The following is a description of a gene set: Although heme is synthesised in virtually all tissues, the principal sites of synthesis are erythroid cells (~85%) and hepatocytes (most of the remainder). Eight enzymes are involved in heme biosynthesis, four each in the mitochondria and the cytosol. The process starts in the mitochondria with the condensation of succinyl CoA (from the TCA cycle) and glycine to form 5-aminolevulinate (ALA). The next four steps take place in the cytosol. Two molecules of ALA are condensed to form the monopyrrole porphobilinogen (PBG). The next two steps convert four molecules of PBG into the cyclic tetrapyrrole uroporphyringen III, which is then decarboxylated into coproporphyrinogen III. The last three steps occur in the mitochondria and involve modifications to the tetrapyrrole side chains and finally, insertion of iron. In addition to these synthetic steps, a spontaneous cytosolic reaction allows the formation of uroporphyringen I which is then enzymatically decarboxylated to coproporphyrinogen I, which cannot be metabolized further in humans. Also, lead can inactivate ALAD, the enzyme that catalyzes PBG synthesis, and ferrochelatase, the enzyme that catalyzes heme synthesis.<br><br>The porphyrias are disorders that arise from defects in the enzymes of heme biosynthesis. Defective pathway enzymes after ALA synthase result in accumulated substrates which can cause either skin problems, neurological complications, or both due to their toxicity in higher concentrations. They are broadly classified as hepatic porphyrias or erythropoietic porphyrias, based on the site of the overproduction of the substrate. Each defect is described together with the reaction it affects. species: Homo sapiens Reactome Pathway: Heme biosynthesis part of: Metabolism of porphyrins, and this is the list of marker genes: FECH, HMBS, PPOX, CPOX, FLVCR1, ALAD, ABCG2 (ATP binding cassette subfamily G member 2 (JR blood group)), UROS, UROD, ALAS2, COX10, ALAS1, COX15, ALB